The following is a description of a gene set: Human Gene Set: GOBP_MRNA_SPLICE_SITE_RECOGNITION Selection of a splice site by components of the assembling spliceosome. species: Homo sapiens, and this is the list of marker genes: RNVU1-4, SETX, CELF6, RNVU1-8, SRSF5, SNRPC, KHDC4, SRSF6, RNVU1-6, LUC7L, PSIP1, CELF1, PUF60, PRPF39, WEE2-AS1, RNVU1-2A, RNU6ATAC, SLU7, SF3A1, CELF5, RNU1-4, RNVU1-14, SF3A2, PTBP2, SF1, CELF2, SRSF9, RNU11, SRSF1, RNVU1-3, SRSF10, SF3A3, NOL3, RNVU1-7 (RNA, variant U1 small nuclear 7), RNVU1-19, RNVU1-1, CELF3, ISY1, YTHDC1, LUC7L2, SFSWAP, LUC7L3, RNVU1-17, CELF4, SRSF12, RNU4ATAC, TAF12-DT, RNVU1-15